Given this list of marker genes JUP, DLG1, RAP1A, CRK, CSNK2A1, WASF2, AKT1, CTNND1, ABI1, CTNNB1, AFDN, TIAM1, ITGAE, CSNK2B, CTTN, VAV2, PIP5K1C, IQGAP1, PIK3CA (NCBI Gene Id 5290), AP1M1, NCKAP1, RHOA, KLHL20, CDC42, ITGB7, ENAH, CYFIP2, CDH1, PIK3R1, CCND1, CSNK2A2, CTNNA1, SRC, RAC1, RAP1B, NME1, TJP1 (NCBI Gene Id 7082), ARF6, RAPGEF1 (Rap guanine nucleotide exchange factor 1), here is a description of the gene set: from publication Schaefer CF, Anthony K, Krupa S, Buchoff J, Day M, Hannay T, Buetow KH (PMID 18832364) studied in species Homo sapiens E-cadherin signaling in the nascent adherens junction Human Gene Set: PID_ECADHERIN_NASCENT_AJ_PATHWAY